The following is a description of a gene set: Genes predicted to be targets of miRBase v22 microRNA hsa-miR-548o-3p in miRDB v6.0 with MirTarget v4 prediction scores > 80 (high confidence targets). from publication Chen Y, Wang X (PMID 31504780) studied in species Homo sapiens Human Gene Set: MIR548O_3P, and this is the list of marker genes: DNAJB2, CAND1, DDX3Y, DCC, TARDBP, USP47, KPNA4, RICTOR, TMEM170A, AKAP11, EEPD1, ABHD17B (abhydrolase domain containing 17B, depalmitoylase), COL25A1, DNAJA2, ARHGAP32, IL1R1, FAM168A, DUSP7, HSPA4L (NCBI Gene Id 22824), PRKAA2, FRS2, UVRAG, MFF, GPM6A, PWWP2A, ABCA8, ARPP19, TTC39C, ARFGAP3, SCAF4, ATP2B1, CASP8AP2, VASP, MYO6, LPP, EEA1, CALU, CD200R1, GRHL2, TLCD5, CRY1, STK38, ZBTB20, RFX2, SULF1, STMN2, ATXN10, XPO4, PAK5, COPS3, FAM151B, BTBD3, KDM7A, SPO11, PATJ, CDK17, CHSY3, FSD1L, TMC7, TKTL2, MIER3, SPTSSA, POMP, GPM6B, CGGBP1, ZBTB33, PRDM10, NFXL1, SMARCA1, AZIN1, KCTD10, CNTNAP4, PRRG1, FAM13C, CAMTA1 (NCBI Gene Id 23261), DENND4A, RNF20, MYNN, SRSF3, SPRED1, PSIP1 (PC4 and SRSF1 interacting protein 1), CLEC7A, PHC3, NUP58, PHIP, NCKAP1, ASIC5 (NCBI Gene Id 51802), VAMP7, TEX30, NAV3, VSIG1, PEX5, TTC33, PPP1R12B, ILRUN, ZBTB10, MAT2B, GOLGA7 (NCBI Gene Id 51125), TBCEL, ZNF286A, CELF2, RCC1, SLC25A36, PRPF40A, NEXMIF, FAM118B, TP53INP1, SPTSSB, YWHAH (tyrosine 3-monooxygenase/tryptophan 5-monooxygenase activation protein eta), ADCY2, ZSWIM6, SCAF11, ATL2, VGLL3, PELI1, CREBRF, SREK1, IKZF5, PTPRO, TTN, ARHGAP21, TMEM135, ARHGEF7, CA8, CPD, KHDRBS1, HMGN2, SS18, TNPO1, IGF2BP3, IRS1, BMPER, ANKRD44, QNG1, AAK1, SECISBP2L, PPTC7, PRMT9, PGAP1, C8orf34, SRGAP1, SRI, AGGF1, LY75, LARP4B, KDM4C (lysine demethylase 4C), ODC1, GRK5, SNRPA1, EFNB1, KLHL7, MBNL3, SLC25A53, ATG14, PRKDC, KMT2C, STK26, SETD4, PLAA, MCM9, SFRP2, UBE2W, TPD52L3, SGCD, RAB1A, LMAN2L, CLOCK, USH2A, ZBTB44, FANCB, MARCHF8, SLAIN2, MAN2A1, ZNF518A, TET3, TOPBP1, CSE1L, CXCL1, SSR1, CFLAR, CNOT1, TNFRSF19, KCTD12, KCNAB1, SERTAD4, ATXN3, STRN3, NR2F2, CDYL, ZNF286B, DPP10, CAMSAP1, RTL6, FOXM1, KIAA0408, KICS2 (NCBI Gene Id 144577), PTPRD, PLD5, UBA5, SMC6, PLGRKT, ANKRA2, PIERCE2, INPP5F (NCBI Gene Id 22876), STRN, FKBP4, ENOX2, ZFHX4, PTPRQ, PIP5K1B, CPB2, JMY, PGRMC1, CMPK1, OSMR, RIDA, GNAQ (G protein subunit alpha q), ATF7IP (activating transcription factor 7 interacting protein), FBXO28, GLCCI1, GID4 (NCBI Gene Id 79018), U2SURP (U2 snRNP associated SURP domain containing), FNIP1 (NCBI Gene Id 96459), EPN2, TEC, PARP1, TGFBR3, KRCC1, B4GALT6, HACD4, METAP1, BNC2, SCN9A, RAD17, DENND1A, RBBP5, ASIC2, SOCS7, LRP2BP, STT3A, TBR1, NTAQ1, HHIP, TSC22D2, TRAPPC8, HMX2, MLLT10, HMGCR, PEG10, ARHGAP29, SLC2A13, GPATCH2L, RPS27L, GLOD4, ZNF615, G3BP2, ACKR3, PABPC4L, GLI3 (GLI family zinc finger 3), DDX3X, DSC2, ZMAT1, MTMR6, GATM (NCBI Gene Id 65211), IL6, CYP3A4, DDX4, SIX4, RTBDN, CDH7, ATAD2B, IVNS1ABP, C2orf49, GINS1, CRMP1, CBLN1, ARL6IP1, PNRC1, IKZF2, PAQR9, PTPRG